The following is a description of a gene set: studied in species Mus musculus Mouse Gene Set: TABULA_MURIS_SENIS_DIAPHRAGM_MACROPHAGE_AGEING from publication Tabula Muris Consortium (PMID 32669714), and this is the list of marker genes: Mmp8, Akt1, H2-Q4, Slpi, Hnrnpa0 (NCBI Gene Id 77134), Retnlg, Rfc2, Tgfb1, Tmsb10, Sord, Cd177, Pglyrp1, Ifitm6, Ccl7, Ptma, Flna, Hmgn2, Phlda1, Cfl1, Cd52, Tacc1, Camp, Serpinb1a, Twf2, Ifngr2, Rps20